The following is a description of a gene set: Reactome Pathway: GRB2 events in EGFR signaling part of: Signaling by EGFR studied in species Homo sapiens Autophosphorylated EGFR tyrosine residues are docking sites for many downstream effectors in EGFR signaling. The adaptor protein GRB2 binds to phosphotyrosine residues in the C-tail of EGFR through its SH2 domain. GRB2 is constitutively associated with SOS, a guanine nucleotide exchange factor of RAS. GRB2 binding to phosphorylated EGFR results in the recruitment of SOS to the plasma membrane where it comes in proximity to RAS. This mechanism has been seen to be the model for RAS activation., and this is the list of marker genes: EPGN, EGF, AREG, BTC, EGFR, KRAS, NRAS, TGFA, SOS1 (NCBI Gene Id 7838), HBEGF, EREG, GRB2, HRAS